Given this list of marker genes P2rx1 (purinergic receptor P2X, ligand-gated ion channel, 1), P2rx2, P2rx6, P2rx4, P2rx7, P2rx3, P2rx5, Ccdc51, Cftr, here is a description of the gene set: species: Mus musculus Enables the transmembrane transfer of an ion by a channel that opens when ATP has been bound by the channel complex or one of its constituent parts. Mouse Gene Set: GOMF_ATP_GATED_ION_CHANNEL_ACTIVITY